The following is a description of a gene set: The chemical reactions and pathways resulting in the formation of glycosylceramides, any compound formed by the replacement of the glycosidic hydroxyl group of a cyclic form of a monosaccharide (or derivative) by a ceramide group. Mouse Gene Set: GOBP_GLYCOSYLCERAMIDE_BIOSYNTHETIC_PROCESS species: Mus musculus, and this is the list of marker genes: B3galt2, B4galt3, Fa2h, B3galt1, Ugcg, Ugt8a, Gal3st1